The following is a description of a gene set: species: Homo sapiens The chemical reactions and pathways resulting in the formation of a pyrimidine deoxyribonucleotide, a compound consisting of nucleoside (a pyrimidine base linked to a deoxyribose sugar) esterified with a phosphate group at either the 3' or 5'-hydroxyl group of the sugar. Human Gene Set: GOBP_PYRIMIDINE_DEOXYRIBONUCLEOTIDE_BIOSYNTHETIC_PROCESS, and this is the list of marker genes: TYMS, SHMT1, DUT, DTYMK, TBPL1, DCTD, CMPK2